Given this list of marker genes COL11A1, LRP5, ATOH7 (atonal bHLH transcription factor 7), COL18A1, NDP, TMEM98, FZD4, here is a description of the gene set: A type of glaucomatous optic neuropathy in an eye that has evidence of angle closure (i.e. significant iridotrabecular contact). studied in species Homo sapiens Angle closure glaucoma Human Gene Set: HP_ANGLE_CLOSURE_GLAUCOMA